The following is a description of a gene set: Any process that results in a change in state or activity of a cell (in terms of movement, secretion, enzyme production, gene expression, etc.) as a result of a mineralocorticoid stimulus. Mineralocorticoids are hormonal C21 corticosteroids synthesized from cholesterol and characterized by their similarity to aldosterone. Mineralocorticoids act primarily on water and electrolyte balance. Human Gene Set: GOBP_CELLULAR_RESPONSE_TO_MINERALOCORTICOID_STIMULUS studied in species Homo sapiens, and this is the list of marker genes: SCNN1B, EDN1, GPER1, FOXO3, SCNN1A, NPAS4, AIFM1, HCN2, SCNN1G, SCNN1D, SGK1, RAN